The following is a description of a gene set: This event has been computationally inferred from an event that has been demonstrated in another species.<p>The inference is based on the homology mapping from PANTHER. Briefly, reactions for which all involved PhysicalEntities (in input, output and catalyst) have a mapped orthologue/paralogue (for complexes at least 75% of components must have a mapping) are inferred to the other species. electronically inferred by orthology from the curated human pathway part of: SLC-mediated transport of oligopeptides Reactome Pathway: Proton/oligopeptide cotransporters studied in species Mus musculus, and this is the list of marker genes: Slc15a1, Slc15a3 (NCBI Gene Id 65221)